Given this list of marker genes MAP3K8, BIRC3, IFITM3, IFI35, TRIML2, CXCL2, SOD2, FAM167A, KRT75, DRAM1, ITGB3, POU2F2, PI3, RELB, HEPHL1 (hephaestin like 1), TCIM, CORO1A, IL6, FEZ1, TNFAIP3, C3, MRGPRX3, KRT6B, NFKBIA, SPRR2A, CXCL8, MMP1, TNFSF14, PDZK1IP1, P2RY6, HELZ2, NRCAM, COL8A1, PARP9, PRDM1, ICAM1, BCL3, C1QTNF1, LIF, RHOF, C1R, EHD1, CHST2, TNFAIP2, NFKB2, IRAK2, RND1, MMP13, CDC42EP2, SPRR2E, ADRB2, MYEOV, STC1, NEDD9, EFNA1, OTUB2, CSF2, PDGFB, BPGM, CFB, IRAK3, SGPP2, IL32, BST2, WFDC21P, PLSCR1, IL36G, TNIP1, OAS3 (NCBI Gene Id 4940, 2'-5'-oligoadenylate synthetase 3), TLCD1, S100P, C1S, S100A7, PLAT, G0S2 (NCBI Gene Id 50486), CCL20, CXCL6, RHOV, LTB, C15orf48, NFKBIZ, IFITM1, IRF7, TRIM47, VNN1, SERPINB1, TUBA1C, PARP12, SLC6A14, PGLYRP4, CSF3, INHBA, IL7R, XDH, IL1B (interleukin 1 beta), PRSS3, TGM2, ADAM8, BMP2, HCAR3, SAA2, IFI44, S100A9, VNN3P, IFIH1, ZC3H12A, RHCG, KRT24, SPRR2D, SAMHD1, LGALS9, IER3, GBP5, ZBED2, TUBB3, CXCL5, TGM1, SOCS3, STAT5A, MAFF, CYP27B1, ZP3, IRF9, SPRY4, S100A8, CXCL1, S100A12, TNF, CRCT1, EDN1, EPSTI1, IKBKE, OAS1, PLAUR (plasminogen activator, urokinase receptor), MUC21 (NCBI Gene Id 394263), DUSP4, TMEM171, OSBP2, SLC25A37, LINC03040, HBEGF, CSGALNACT1, SPRR1A, OAS2, here is a description of the gene set: from publication Blanco-Melo D, Nilsson-Payant BE, Liu WC, Uhl S, Hoagland D, Møller R, Jordan TX, Oishi K, Panis M, Sachs D, Wang TT, Schwartz RE, Lim JK, Albrecht RA, tenOever BR (PMID 32416070) species: Homo sapiens Genes up-regulated on infection of normal human bronchial epithelial cells by SARS-CoV-2 (MOI: 2, 24hpi) Analysis of the transcriptional response to SARS-CoV-2 compared with other respiratory viruses, including MERS-CoV, SARS-CoV-1 (SARS), human parainfluenza virus 3 (HPIV3), respiratory syncytial virus (RSV), and IAV. Human Gene Set: BLANCO_MELO_COVID19_BRONCHIAL_EPITHELIAL_CELLS_SARS_COV_2_INFECTION_UP